Given this list of marker genes ZFPM2, HYLS1, GATA6, EFEMP2, LONP1, here is a description of the gene set: Human Gene Set: HP_APLASIA_HYPOPLASIA_OF_THE_DIAPHRAGM species: Homo sapiens Aplasia/Hypoplasia of the diaphragm Absence or underdevelopment of the diaphragm.